The following is a description of a gene set: Human Gene Set: MIR1258 studied in species Homo sapiens Genes predicted to be targets of miRBase v22 microRNA hsa-miR-1258 in miRDB v6.0 with MirTarget v4 prediction scores > 80 (high confidence targets). from publication Chen Y, Wang X (PMID 31504780), and this is the list of marker genes: PAK5, WWTR1, PCNP, C12orf76, CKS1B, MEIOC, TMEM68, SPEN, HOOK3, PHF20L1, VCF2, ZNF547, AQP1, PRLR, RNF144A, ANXA3, GDPD1, PRP4K, ASPH (NCBI Gene Id 56921), FASLG, ZNF100, AZIN1, S1PR3, RNF17, LARP4B, CLIC4, SERPINB7, ATG12, DNER, DLG5, ASH1L, PTBP3 (NCBI Gene Id 9991), MTMR1, MYH9, GALNT8, EXD1, PCSK1, CSTF3, RYBP, GNG2, MBP, RNF103, HOXD10, EMX2, PMP22 (NCBI Gene Id 5376), SLC30A7, UBE2H, MS4A1, ZIC4, BMPR2, ZBTB44, NHLRC3, ITPKB, BBS7, TGFBR1, MBTD1, EBF2, KLHL32, HERPUD2, SERPINB8, SGMS1